The following is a description of a gene set: from publication He P, Lim K, Sun D, Pett JP, Jeng Q, Polanski K, Dong Z, Bolt L, Richardson L, Mamanova L, Dabrowska M, Wilbrey-Clark A, Madissoon E, Tuong ZK, Dann E, Suo C, Goh I, Yoshida M, Nikolić MZ, Janes SM, He X, Barker RA, Teichmann SA, Marioni JC, Meyer KB, Rawlins EL (PMID 36493756) Human Gene Set: HE_LIM_SUN_FETAL_LUNG_C2_SPP1_POS_MACROPHAGE_CELL studied in species Homo sapiens SPP1+ Mφ, and this is the list of marker genes: CD209, PLTP, SLCO2B1, FAM20A, VSIG4, HPGDS, ABCC5, HOMER3, MERTK, CD28, COLEC12 (NCBI Gene Id 81035), BLVRA, AGR2, MTUS1, SCN9A, HRH1, ITSN1, C1QB, RCN3, NRP1, IGFBP4, PCDH12, RNASE1, LYVE1, TMEM37 (NCBI Gene Id 50627), SLC12A5, TNFRSF25, WWP1, SLC7A8, IGF1, LILRB5, ITGB5, SELENOP (NCBI Gene Id 6414), SIGLEC1, SPP1 (NCBI Gene Id 6696), EGFL7, PLEKHG5, CD163L1, MAN1A1, NPL, CCL2, A2M, CTSL, RAB3IL1, NRP2, ABCG2, ABCA1, C2